The following is a description of a gene set: Any process that stops, prevents, or reduces the frequency, rate, or extent of type I interferon production. Type I interferons include the interferon-alpha, beta, delta, episilon, zeta, kappa, tau, and omega gene families. studied in species Mus musculus Mouse Gene Set: GOBP_NEGATIVE_REGULATION_OF_TYPE_I_INTERFERON_PRODUCTION, and this is the list of marker genes: Dhx58, Sirpa, Traf3ip1, Ppm1b, Gbp4, Crebbp, Qki, Peli3, Tyrobp, Nlrx1 (NCBI Gene Id 270151), Gbp7, Havcr2, Atg9a, Xaf1 (XIAP associated factor 1), Ptpn11, Ilrun, Relb, Rbx1-ps, Atg5, Ddx56, Acod1, Kat8, Cactin, Traip, Klhl22, Cul3, Siglec1, Gpatch3, Ufd1, Rnf125, Nlrc3, Nploc4, Atg12, Yy1, Rel, Irgm1, Nmi, Trim27, Banf1, Irgm2, Ptprs, Rbx1, Igtp, Pycard, Morc3